Given this list of marker genes SH3TC2, KLHL41, HERC2, COL6A1, POLG, SNORD116-1, MYO1H (myosin IH), MAGEL2, SLC52A3, MECP2, NEB, DMD, PWRN1, MKRN3, FKRP, EIF4A2, NDUFAF2, SELENON, CFL2, RET, COL12A1, COX11, NDUFS6, MYH7, COL6A3, DNAJB4, LAMB2, PURA (purine rich element binding protein A), SNORD115-1, NPAP1, DCTN1, COL6A2, CRLS1, ASCL1, DZIP1L, PHOX2B, LAMA2, ACTA1, LBX1, TPM3, COLQ, SLC5A7 (solute carrier family 5 member 7), HOXA1, PKHD1, TTN (NCBI Gene Id 7847), LMOD3, PWAR1, TPM2, P4HTM, MYPN, MOGS, HNRNPK, SETD2, here is a description of the gene set: A reduction in the amount of air transported into the pulmonary alveoli by breathing, leading to hypercapnia (increase in the partial pressure of carbon dioxide). Human Gene Set: HP_HYPOVENTILATION studied in species Homo sapiens Hypoventilation